Given this list of marker genes VTRNA1-1 (NCBI Gene Id 56664), FZD1, ENSG00000255491, MRPL9, POM121, PARVG, PCBD2, GGA3, INO80B-WBP1, EIF4ENIF1, INTS12, NAMA, SEPTIN7P14, MRPL28, PXMP2, POLR2E, SLC11A1, CACTIN, DNAJC28, BABAM2, STIMATE (STIM activating enhancer), E2F4, MYBPC1, NHLRC3, PRMT5, H3C9P, SLAMF8, RPL35A, LNX1, MFAP3L, MED29, IQGAP3, RNU6-813P (RNA, U6 small nuclear 813, pseudogene), DYNC1LI2-DT, ARID3A, TNS3, NCLN, BMF, TRIM7-AS2, AVIL, ADH1C, TRIB3, HEY1, RN7SL108P, POM121C, PI4KB, LINC02002, CWC25, MGAT5, TSN, PRDM1, DNAJB6P2 (NCBI Gene Id 650531), SNORD58B, EXOSC5, B4GALT5, RNVU1-15, EIF4A1P7, PPP3CB, TTLL4, AIMP1, ENSG00000238185, MTCH1, RAB31, CHROMR, ACAT1, USP4, JARID2-DT, APOL3, RWDD1 (NCBI Gene Id 82733), ATP6AP1L, CELF3, ELF2P3, VDAC2, KLRC4-KLRK1, FABP3, MTFR1, LINC02207, RIIAD1, EBI3, DCAF11, RABGGTB, ARHGAP11A-DT, RNU6-163P, RPL7, DYNLT4, SNORD50B, MTFP1, EFTUD2, REXO1, DDX51, GTF2IP12, ATP6V0A1, ACYP1, SLC19A2, KAT7, VTRNA1-2, SPMIP6, GOLGA5, ENSG00000235978, CFLAR-AS1, PPP2R1B, PRKAR2B, ATP6V0D1, TMC6, SEC61B, LINC02888, ATP5MG, JARID2, RPL21, SUCLG1, TAF9, BUD31, CDKN2AIP (CDKN2A interacting protein), EMC1, LINC02918, RDH10, UPF1, NKPD1, SLC25A6, VWA5A, SNX33, DZANK1, ZC3H18 (NCBI Gene Id 124245), MYNN, EWSR1, GOSR2-DT (GOSR2 divergent transcript), CLHC1, GADD45GIP1, C1QA, VPS35L, PROSER1, RAB39B, ZNF585B, SELENOF, TXNIP, EIF2AK3, GSN, CRPPA-AS1 (CRPPA antisense RNA 1), UBR1 (ubiquitin protein ligase E3 component n-recognin 1), STAM2, DAAM1, PPP3CB-AS1, DDX39B, COPS3, PEAK3, CEP97, KCTD10, SLA, RBAK-RBAKDN, MAPKAPK5-AS1, HSPA9, MIR4727, PSMG2, RBMS3, LINC02832, PDAP1, LINC00399, MIR4495, OGFRL1, SMAP2, AP3M1, RGS18, MRPS7, TSKU, AOAH-IT1, RPS29, ICE1, CIITA, CNOT9, ALG2, DNASE2B, ABHD12, RPAP1 (RNA polymerase II associated protein 1), LINC00582, JADE1, EIF2S3, SRD5A1, KRT13, DCTN1, ZFP1, PTGES2, ZMYND8, GPX3, BCKDHA, AP3S1, GSN-AS1, MIR302A, DYNC1LI2, SLC11A2, LINC01354, NDUFA4, CFAP418, CFDP1, MRPS5, NFATC3, RPS23, RPS12, SNORD101, SCAT2, BZW1, KCNE1 (NCBI Gene Id 3753), GORAB, CD55, ENSG00000249236, LGALS3BP, POLR3F, CHRND, RHBDD3, NVL, RNU5E-1, KLRC2, COMMD1, RNU5E-4P, TIPARP-AS1, HS1BP3-IT1, TIGD5 (tigger transposable element derived 5), ALOX5AP (arachidonate 5-lipoxygenase activating protein), RNU6-1, GPAT4-AS1, AQP4-AS1, SLC1A3, ADH7, RPL17-C18orf32, RPL23AP82, SNX27, UBALD2, ZFHX4-AS1, PELATON, IRGQ, NDC1, MIR199A1, DDX39B-AS1, TSNAX, JRK, NIPAL2, SRRM5, NRP1, RCC1, NEAT1, EEF1A1, CAVIN2 (NCBI Gene Id 8436), DNAAF10, DPH6, AVL9, ST13, TMIGD3, PIN4, ATF6, SLC45A4, FMN1, CAMKK1, SCAP, NDUFA10, SF3B3, NUP85, PCBP1-AS1, CHIC2, PSMD9, PTGES2-AS1, RNU5B-1, RNY3P11, RNF121, PES1, CNPY2, UFM1, AGPAT1, LOXL2-AS1, NUP205, ABCC1, ABCB9, CEP76, ENSG00000201701, FAM83A-AS1, UBE3B, ATF6-DT, APEX1, GPR137B, STAM-DT, MIR302CHG, S100B, ABCG1, MECP2, DUS1L, RN7SL813P, ST3GAL1, XNDC1N, RPL23AP7, CXCL16, DRAP1, PSME2P2, RPL26P13, RPS27A, SLC35B1, ILF2, SART3, PRKRIP1, NFE2L1, CAPRIN1 (NCBI Gene Id 4076), SACM1L, MMP8, BLM, ENSG00000266976, POLE, SNORD45C, NCEH1, PSMD1, IPO13, EPB41L3, CALCOCO2, TMED1, SNX15 (NCBI Gene Id 29907), THADA, MAPKAPK5, C19orf38, SEC11C, ZNF653, LINC02739, CTTNBP2, CXCL8, ADAMDEC1, GOSR2, TCF7L2, PPP6R3, MIR30C2, TIPARP, STAM, ZNF576, REEP5, MYOSLID, TTC39A, TSKU-AS1, UPF2, CDKN2AIPNLP3, MFSD6, SNORD48, ARAF (NCBI Gene Id 369), LINC02745, CUEDC1, ZBED3-AS1, RND3, RXYLT1, LYAR (Ly1 antibody reactive), ACACB, ZC2HC1C, OGFOD2, SLC39A13, C6orf52, ZC3H12D, MIR302D, OLAH, LRR1, STIMATE-MUSTN1, LINC03108, RBKS, SLCO2B1, LIMD1-AS1, LINC01623, SYNGR2, PCBP1, MIR802, RNU6-720P, OSGEP, RHEX, RNVU1-14, LYSMD1, RABL2B, TPRA1, JPT1P1, SNHG3, HOXA13, ALOXE3, RABL2A, TTC8, PAK1IP1, SMARCD3, GORAB-AS1, MIR7848, ADK, ITIH1, MRTO4, ZNF329, SKP1, COX7A2L, CCDC103, PLIN2, LGR4, LILRA2P1, C19orf48P, RBBP5, SMC2, ENSG00000253177, WASHC4, RAD17, FARS2, UBE2I, BAG6, SLC2A5, POLR3E, MEF2C, PNO1, PACSIN2, MRPL11, SUDS3, SPON2, SNHG5, RPN1, ST7L, SEC14L2, ECHDC3, PSMD12, NISCH, GGCX, VTI1B, LINC02683, LRP3, CCT4, TM9SF1, P2RY12, RNU6-565P, RPRM, C19orf84, RGS19, BLCAP, ACACA, BAIAP2, SLC8A1-AS1, CCDC106, ATG12, RTN4IP1, IQCG, VPS8, DPH6-DT, PRKAB1, ENSG00000267882, EEF1A1P18, XPO6, RBAK, RCL1, ELMO2, HADHB, RNU6-150P, HK1, PDK4-AS1, TSNAX-DISC1 (TSNAX-DISC1 readthrough (NMD candidate)), SAP30, NOC4L, CYTIP, SUPT3H, SPATC1, TMED10, KLF13, ENSG00000258926, ZNF383, EEF1D, PLXDC1, SLC40A1, LNPPS, LASP1, HS2ST1, LCP1, HUS1, USP37, MIR1208, TMEM218, RELA, CCDC57, ESRRA, ZRANB2-DT, FAM187A, ARHGAP11A, LINC01962, ENSG00000233461, PKP2, ENSG00000214803, SCNM1, NSUN2, RBMS3-AS3, ARHGEF2, XPNPEP3 (X-prolyl aminopeptidase 3), HSPA1B, ST3GAL5, ZRANB2, TMSB10, ZDHHC4, TBCK, RCAN1, ENSG00000273077, SLAMF6P1, VCF1, LINC02600 (NCBI Gene Id 107986251), MIR3202-2, INO80B, RHOBTB2, ZFAND5, TBCD, AHCYL2, MARVELD1, AK6, MTNAP1, MMP2, RNF225, RNU6-904P, BCAR3, ITGA11, RNU5A-1, LINC00964, SUPV3L1, RPL17, FGGY, AMN1 (antagonist of mitotic exit network 1 homolog), PTPN11P3, NME6, PIAS3, RASGEF1C, SRPX, ZNF12, TMEM87B, MT2A, C11orf68, MSANTD2 (NCBI Gene Id 79684), ARID2, DECR1, LYRM4, AXDND1, LINC02319, SNHG32, ACTR10 (actin related protein 10), MIR302C, MIR367, CCDC162P, COG4 (component of oligomeric golgi complex 4), PABPC1, NT5C2, GSAP, TEX2, VLDLR-AS1, HADHA, OAZ3, S100A10, here is a description of the gene set: Human Gene Set: NCOA2_TARGET_GENES species: Homo sapiens from publication Yevshin I, Sharipov R, Kolmykov S, Kondrakhin Y, Kolpakov F (PMID 30445619) Genes containing one or more binding sites for (NCOA2) in their promoter regions (TSS -1000,+100 bp) as identified by GTRD version 20.06 ChIP-seq harmonization.